The following is a description of a gene set: species: Homo sapiens Human Gene Set: GSE29949_MICROGLIA_VS_DC_BRAIN_UP Genes up-regulated in brain: microglia versus dendritic cells. from publication Anandasabapathy N, Victora GD, Meredith M, Feder R, Dong B, Kluger C, Yao K, Dustin ML, Nussenzweig MC, Steinman RM, Liu K (PMID 21788405) To understand the functional relationship between brain dendritic cells (brain DCs) and other myeloid cells, we compared the gene expression profile of m/chDCs to that of bone marrow monocytes, brain microglia and classical spleen CD8+ and CD8- DCs. In order to obtain enough brain DCs for mRNA extraction, we expanded brain DCs with in vivo Flt3L treatment before purification., and this is the list of marker genes: SBSPON, YIF1A, IFNA1, SLAMF1, UAP1, HLTF, GPX4, ELL2, TLE4, MAP3K4, ANK2, ACAA2, FAM89B, BMPR2, FXR1, HOXA11, FURIN, CDKN1A, DDIT4, CCN6, PTPN21, HYAL1, SEC62, HAUS3, BMP2K, MARCHF2, PARP1, REL, LOXL1, SERPINB10, CSTF2T, IL6 (interleukin 6), GOT2, AGPAT1, HMX1, PRDX1, SLC7A6, EIF4E, CTDP1, JTB (jumping translocation breakpoint), ATF3, GDI2, CHD8, GSPT1, DDX39A, NEFM, SOD3, TGFB1 (NCBI Gene Id 7040), PPM1B, CCND2, SLC35D2, PRRC2B, LIG4, DHX8, ABHD5, SHOX2, TACSTD2, H1-4, TUBA4A, CIC, LAPTM5, GNMT, ZNF460, LPGAT1, DYRK3, CD79A, GRB10, CTSL, HBEGF, SS18, RGS16, BBC3, CRISP2, GADD45G, LIPT1, BHLHE40, RAB11FIP3, IL1RAP, TATDN2, CCL20, GNPDA1, PTPN22, CD2, ANKRD26, AGR2, LCP2, TPD52L2, H3-3B, DNAJC9, LRPPRC, MKNK1, CCHCR1, FLOT2, CD3D, MDFIC (NCBI Gene Id 29969), BASP1, STRAP, LGI1, PTPRR, PLD3, FMR1, FLII, CAMSAP2, NGDN, COG4, SRP54, CD6, TGIF1, WWC1, VDR, ZW10, MAP2K4, PPP1R2, JUN, OLR1, IFNGR1, OSBPL8, GYS1, SLA, VGLL4, HUWE1, SSUH2, SPHK2, EPHB6, TNK2, TRPC6, DEPP1, DLAT, COX7A1, MAB21L1, SOX4, PLP2, ARPP19, NR4A1, HOXA4, IER2, CXCR5, GSTO1, EIF3A, ASGR1, SMARCA1, S100A10, SSX2IP, TNFSF11, TIAM1, CBFB, GEM, NECTIN3, ATP2A1, UBTF, IHH, CREBZF, COL18A1, FAM169A, LTBP4, ACSL1, CA2, LIF, G3BP1, ALG13, IGFBP4, NR0B1, CLDN3, SLC7A5, DZIP1, ADAM9, CEACAM6, LAPTM4B, COL6A3, CPVL, F5, RRP12, NR0B2, GIT2, CD58, ATP1B1, PDXK (pyridoxal kinase), JUNB, PHLPP2, TNFAIP8, PRPF3, CLTCL1, CD44, COBLL1, ZNF267, SREK1, MYC, SUSD6, GCHFR, MAP4, MINPP1, ADAM19, SSPN, EIF1, RET, ALKBH1, H1-2, RALGAPB (NCBI Gene Id 57148), KALRN